Given this list of marker genes Kcnc3, Kcnc2, Epb41l3, Slc1a2, Myo1d, Ank1, Chrna7, Mapk8ip3, Cntnap2, Robo2 (roundabout guidance receptor 2), Kcnh1, Thy1, Kcnj11, Mapt, Gabbr1, Kcnc1, Adora1, Sptbn1, Robo1, Adora2a, here is a description of the gene set: The portion of the plasma membrane surrounding an axon; it is a specialized trilaminar random mosaic of protein molecules floating within a fluid matrix of highly mobile phospholipid molecules, 7-8 nm in thickness. Mouse Gene Set: GOCC_AXOLEMMA studied in species Mus musculus